The following is a description of a gene set: Human Gene Set: GSE13887_RESTING_VS_ACT_CD4_TCELL_DN Genes down-regulated in CD4 T cells from healthy donors: resting versus activated by anti-CD3 and anti-CD28. from publication Fernandez DR, Telarico T, Bonilla E, Li Q, Banerjee S, Middleton FA, Phillips PE, Crow MK, Oess S, Muller-Esterl W, Perl A (PMID 19201859) CD3-positive T cells were negatively isolated from 10 SLE patients and 9 healthy controls without SLE. All of the SLE samples and control samples were compared with one another to identify baseline differences in expression due to the disease. Next, T cell preparations from 4 of the control subjects were stimulated with either Nitric Oxide (NOC-18) 600 uM for 24hr or stimulated through CD3/CD28 for 24hr to determine which genes were responsive to these signaling mechanisms. Here, we show that activity of the mammalian target of rapamycin (mTOR), which is a sensor of the mitochondrial transmembrane potential, is increased in SLE T cells. Activation of mTOR was inducible by NO, a key trigger of MHP which in turn enhanced the expression of HRES-1/Rab4, a small GTPase that regulates recycling of surface receptors through early endosomes. Expression of HRES-1/Rab4 was increased in SLE T cells and, in accordance with its dominant impact on the endocytic recycling of CD4, it was inversely correlated with diminished CD4 expression. HRES-1/Rab4 over-expression was also inversely correlated with diminished TCRζ protein levels. Combined with follow up studies, these results suggest that activation of mTOR causes the loss of TCRζ in lupus T cells through HRES-1/Rab4-dependent lysosomal degradation. studied in species Homo sapiens, and this is the list of marker genes: RDH5, KLC2, HECTD3, E4F1, KRT6B, LNX2, FBXO8, IRF5, FAM163A, HYCC1, ALG12, TEX9, NEPRO, CCNK, ZNF394, ARHGAP29, GRXCR1, APTX (NCBI Gene Id 94135), TSPAN2, PDE6A, FUS, SRP72, CDKN2AIP, HGD, IDI1, C1D, CAPZB, NCAM2, MAP2K6, ABHD2, IL18RAP, IRAK3, FLVCR2, HMGCS1 (3-hydroxy-3-methylglutaryl-CoA synthase 1), DPP3, NUP42, KBTBD7, DENND6B, IGSF10, PRKAB1, ORM1, POGLUT3, CBFA2T2, VSIG4, MAN1B1, LIMS1, VPREB1, GHR, TERF2IP, ARSG, PARP3, POLB, LYPLAL1, NIPSNAP2, SEH1L, GGCX, CUEDC1, HLCS, IKBKG, SCARNA17, NEXN, MAN2A2, AHCYL1, HINFP, SARNP, NUB1, BTRC, KLHL26, MCOLN3, PADI4, NSA2, TRMT2B, IFT140, FGGY, KYAT1, CORO6, VSIG10L, ITGAL, C16orf89, CHMP2B, GLRX, MRPL47, SUN1, PCDHB9, MLH1, MAPK14, CCS, ADAM32, IRF7, CASP2, METTL21A, PTMA, BPHL, DTX3, IL1RL1, RPL29, KLHDC2, MAPK6, ANXA1, SPPL3, NOD2, CD5, HSPA13 (NCBI Gene Id 6782), GPRIN1, BMP2, SUB1, SMCR8, CFAP58, CDK5RAP1, CPNE8, EDA, MIR450B, TRIM55, MKRN3 (NCBI Gene Id 7681), WDR12, EBF1, HNRNPF (heterogeneous nuclear ribonucleoprotein F), ARRDC1, LILRB3, ITGB1BP2, ALG6, NAT1, UNC50, ITGB8, ETS2, LRRTM4, SLC26A4, NUDT16, XDH, PLEK2, USP9Y (NCBI Gene Id 8287)